Given this list of marker genes Trip11, Foxi1, Fgfr1, Zic1, Rpgrip1l, Esrp1, Gabra5, Ptprq, Gabrb3, Alms1, Esrrb, Fgf20, Otogl, Slc17a8 (solute carrier family 17 (sodium-dependent inorganic phosphate cotransporter), member 8), Myo3b, Bmper, Psap, Notch1, Clrn1, Cxcl14, Anp32b, Rpl38 (NCBI Gene Id 67671), Spag6l, Tmc1, Igfbp7, Bmp2, Neurod1, Tbx3, Clic5, Pls1, Sox9, Atg5, Tfap2a, Frzb, Nectin1, Wnt5a, Pi4kb, Nherf1, Fgfr2, Gfi1, Nkx3-2, Celsr1, Otop1, Frem2, Bmp5, Enpp1, Hes5, Mcm2 (minichromosome maintenance complex component 2), Hey2, Epha4, Pou3f4, Hoxa2, Myo7a, Lrig3, Adgrv1, Mycn, H2-T23, H2-T10, Adam10, Shroom2, Kcnq4, Tbx18, Elmod3, Ttc39c, Gli2, Lrp10, Jag1 (NCBI Gene Id 170642), Atp2b2, Pou4f3, Bdnf, Lhfpl5, Dicer1, Fgf9, Lhx3 (NCBI Gene Id 16871), Ptk7, Tsku, Tecta, C1qb, Spry2, Fgfr3, Ttc8, Foxg1, Ush1c, Kcnk2, Gata3, Ift88, Gjb2, Otx2, Dvl2, Hoxa1, Kcnk3, Prkra, Mks1 (MKS transition zone complex subunit 1), Fgf3, Clrn2, Hey1, Diaph3, Tbx1 (NCBI Gene Id 21380), Cep290, Insig2, Chrna10, Rest, Dvl3, Hpca (hippocalcin), Eya1, Gsdme, Alg10b, Cecr2, Ror1, Atg4b, Blvra, Ifi204, H2-K1, Hesx1, Bloc1s5, Whrn, Oc90, Hpn, Scrib, Atp8b1 (NCBI Gene Id 54670), Mcoln3, Tifab, Cdh23, Pdzd7, Ece1, Ankrd24, Col2a1, Atp8a2, Itga8, Dlx5, Fat4, Gabrb2, Minar2, Fgf10, Osr1, Rubie, Col11a1, Nipbl, Strc, Neurog1 (neurogenin 1), Ripor2, Fzd2, Slc26a5, Tshz1, Kif3a, Maf, Dchs1, Sod1, Wdpcp, Nr4a3, Sobp, Phox2b, Pjvk, Ptpn11, Ddr1 (discoidin domain receptor family, member 1), Six4, Gas1, Stra6 (NCBI Gene Id 20897), Hes1, Ush2a, Gli3, Aldh1a3, Bcl2, Mycl, Fgf2, Hoxa13, Zeb1, Vangl2, Tomt, Dll1, Wnt1 (NCBI Gene Id 22408), Stox1, Ush1g (USH1 protein network component sans), Mpv17, Prox1, Kcnma1, Sox2, Tcap, Slc44a4, Gata2, Slc4a7, Gbx2, Cys1, Shh, Insig1, Fgf8, Sec24b, Zic3, Ednra, Jag2, Myo3a, Fzd3, Atp6v1b1, Pax8, Tmie, Pafah1b1, Ift27, Rac1, Dvl1, Cytl1, Ccna2, Myo15a, Triobp, Otog, Wdr19, Fzd6, Lrig1, Hmx3, Bcl2l11, Gjb6, Get1, Plppr4, Mapk3, Rdh10, Msx1 (NCBI Gene Id 269644), Grhl3, Nox3, Tgfb2, Abr, Cebpd, Mapkapk2, Prrx2, Grxcr1, Ephb2, Nog, Wnt3a, Gsc, Ift20, Sparc, Bmp4, Tshr, Tcf15, Nectin3, Cebpa, Igf1, Six2, Naglu (alpha-N-acetylglucosaminidase (Sanfilippo disease IIIB)), Six1, Eya4, Osr2, Prrx1, Ntn1, Otol1, Tprn, Kcnq1, Chrna9, Chd7, Grxcr2, Rbpj, Mafb, Ocm, Myo6, Ccm2, Tgfb1, Bcr, Cdkn1b, Pcdh15, Mir96, Mapk1 (mitogen-activated protein kinase 1), Cux1, Nfix, Calb1, C1qtnf5 (C1q and tumor necrosis factor related protein 5), H2-DMa, Lin7a, Atoh1, Cdh1, Hmx2, Duox2, Slitrk6, Sdc4, Lgr5, Tbx2, Pax2, Myc, Dlx6, Otx1, Edn1, Cthrc1, Ror2, here is a description of the gene set: species: Mus musculus Mouse Gene Set: GOBP_EAR_DEVELOPMENT The process whose specific outcome is the progression of the ear over time, from its formation to the mature structure. The ear is the sense organ in vertebrates that is specialized for the detection of sound, and the maintenance of balance. Includes the outer ear and middle ear, which collect and transmit sound waves; and the inner ear, which contains the organs of balance and (except in fish) hearing. Also includes the pinna, the visible part of the outer ear, present in some mammals.